Given this list of marker genes P2RY1, P2RY12, P2RY2, LPAR6, LPAR4, P2RY10, GPR17, P2RY6 (NCBI Gene Id 5031), P2RY11, P2RY13, P2RY4, P2RY14, here is a description of the gene set: Human Gene Set: REACTOME_P2Y_RECEPTORS species: Homo sapiens P2Y receptors